The following is a description of a gene set: species: Homo sapiens Antigen processing: Ubiquitination & Proteasome degradation Human Gene Set: REACTOME_ANTIGEN_PROCESSING_UBIQUITINATION_PROTEASOME_DEGRADATION, and this is the list of marker genes: ASB15, LRRC41, UBE2E1, FBXO15, RNF130, FBXO2, RBBP6, RNF220, FBXW11, HERC2, MYLIP, UBE2D1, PSMC1 (proteasome 26S subunit, ATPase 1), FBXW12, FBXL4, UBE2U, TRIM36, UBE2H, SIAH2, RNF7, RLIM, PSMC3, UBE2Q2, TRIM4, RNF111, PSMD8, TRIM37, UBB, UBE2G2, KLHL25, ANAPC4, FZR1, UBE3C, ASB2, ELOC, TRIM71, UBC, HECW2, FBXW5, KEAP1, UBE2J2, DCAF1, PJA2, ANAPC1, HERC5, PSMB2, ASB13, LTN1, UBE2Z, KBTBD8, UBE2V2, UBA5, ADRM1, UBA7, PSMD13, KLHL13, TRAF7, FBXW8, FBXW10, ASB12, CUL1, ASB18, FBXO21, ASB6, ANAPC10, UBE2L3, SIAH1, TRIM21, RNF144B, LNPEP (leucyl and cystinyl aminopeptidase), PSMD6, HERC4, FBXL18 (NCBI Gene Id 80028), CUL5, FBXL3, DZIP3, SMURF2, ASB4, UBE2N, PJA1, FBXL8, SOCS1, KLHL11, PSMB3, UBA52, CDC27, UBAC1, RBX1, ASB7, RNF123, FBXW7, FBXO41, TRIM11, ASB11, PSMA3, PSMD7, ITCH, KBTBD13, PRKN, MGRN1, RNF41, PSMD12, UNKL, RNF138, UBE2D3, FBXO30, BLMH, RNF126, NPEPPS, RPS27A, RNF6, KLHL5, AREL1, KLHL9, LNX1, LRSAM1, ASB5, LMO7, PSMB5, PSMC5, ANAPC11, FBXL15, UBE2D4, KLHL3, PSMA7, BTRC, ZNRF2, UFL1, DET1, ASB10, RNF34, PSMA5, LRR1, ANAPC5, PSMB1, CDC23, CBLB, UBR1, FBXO40, DTX3L, FBXL13, UBE2Q1, FBXO7, FBXO11, THOP1, FBXL7, CUL2, PSMD3, PSMA1, UBE4A (ubiquitination factor E4A), CUL7 (cullin 7), RNF182, ARIH2, FBXL5, FBXO9, TRIM32, FBXL20, LONRF1, PSMC6, FBXL12, FBXW9, UBE2E2, UBA1, CDC20, FBXL19, RNF14, PSMD11 (proteasome 26S subunit, non-ATPase 11), SH3RF1, KCTD7, MEX3C, FBXO22, ELOB, MIB2, UBE3A, FBXO27, PSMC4, RNF19A, TRIM9, UBR4, RNF4, SKP2, NEDD4L, UBE2W, RNF217, RNF19B, PSMD2, FBXO17, RNF114 (NCBI Gene Id 55905), CCNF, UBE2G1, BTBD1, TRIM63, CDC16, KLHL20, ANAPC2, ASB16, UBE2L6, GAN, UBE2F, TPP2, UBE3B, SPSB2, PSMC2, RNF25, KLHL21, RCHY1, KBTBD6, UBE2R2, PSMB7, PSMD1, UBE2E3, ASB17, TRIM50, TRIM41 (NCBI Gene Id 90933), UBE2D2, UBA6, FBXL16 (NCBI Gene Id 64481), KCTD6, PSMA2, UBE2M, WWP1, ASB1, PSMB4, UBE2C, GLMN, FBXO32, KLHL2, RBCK1, FBXW2, FBXO31, UBE2O (NCBI Gene Id 63893), CDC26, SOCS3, MKRN1, UBE2J1, ATG7, RNF213, HERC1, HERC6, UBE2K, SEM1, PSMA6, UBE2B, KLHL22, SPSB4, FBXO44, CBLL2, UBE2A, BTBD6, KLHL42, VHL, KLHL41, ANAPC13, FBXL22, RNF115, UBE2V1, WSB1, SKP1, ASB9, TRIM69, UBE3D, HUWE1, SMURF1, CDC34, TRIM39, FBXW4, HERC3, ZNRF1, ASB8, SPSB1, ANAPC7, NEDD4, UBE2S, ASB14, FBXO10, PSMB6, STUB1 (STIP1 homology and U-box containing protein 1), HECTD3, ASB3, UBOX5, TRIP12, ZBTB16, CUL3, KBTBD7, FBXO4, HACE1, FBXO6, FBXL14, PSMD14, PSMA4, HECTD2, HECTD1, UBR2, UBA3, TRAIP